Given this list of marker genes ODF4, TSPYL2 (TSPY like 2), ZRANB2, CALML5, ABAT, LRGUK, KRTAP1-5, MIR155HG, TNFSF9, DUSP2, CCDC177, IRF8, ZNF287, MAP3K8, ADGRB2, CPNE5, ADIRF, IGFBP7-AS1, MAGEA6, TPBG, LRRC61, EXT1, LINC02381, G0S2, PLA1A, CDKN2A, CPEB1-AS1, POLR1C, PDGFA, SOCS2, CDKN2B, C3orf36, ZNRF4, DEPDC7, SOST, NETO2, WDR86, ADA, SPRR2C, KHDC1L, RAB21, GSX2, DENND4A, PNLIPRP3, DUOX2, TNF, RPGR (NCBI Gene Id 6110), ZIM3, EPHB4, FSD1L, NDUFAF2, TRIP10, POLR3C, TFPI2, CD320 (CD320 molecule), TLR4, RHCG, GPRC5A, NFKBIZ, IFNG, CDK2, GADD45A, STEAP1B, CCNYL2, NEFH, INSM2, UBE2E1, VXN, FXYD6, SVIL, SLC5A1, TMEM243, IL36B (interleukin 36 beta), FOS, RALA, CNKSR3, NOCT, ARHGDIG, SLC24A2, RAB39B, ATG101, SEMA3A, MAPKBP1, TESC, CNFN, SIK1, PAPPA2, LIF, SENP5, PCDHB18P, LRRC49, RPL21, IQCG, PGLYRP2, HECW2, PIM2, ADORA2B, ZFPM2, RAB30-DT, POPDC2, BCL2L1, NEMP1, MSTN, CREB3L1, GPR101, CLCF1, ARL5B, SIM2, SCARNA2, FOXP1, OLFM4 (NCBI Gene Id 10562), SELENOM, RGS16, CD70, HSD3B2, CREB5, KLF2, NDE1, ECD, DUSP4, PRKCZ, SLC2A5, NODAL, TPM2, TLCD3A, HPN, LOXL1, LIPG, SAMD10, OXTR, PERP (NCBI Gene Id 64065), SELENOK, PAX2, PLEKHA3, TDH, MED14, DUSP1, SCART1, PROSER2, EGR3, DYRK3, TRAF4, ETS2, CAPN8, C20orf96, IL23A, BICDL1, MPZL1, DDN, ZNF239, C7orf33, KIF14, CYRIA, ACOT11, AGT, IL12A, NOTCH3, IRX3, TARP, H4C7, LINC-PINT, MAD2L1, KHDRBS3, TMEM156, FJX1, NLRP7, NIM1K (NIM1 serine/threonine protein kinase), BCL2L14, VSIG4, ZXDA (NCBI Gene Id 7789), TRIM69, CAMK1G, BACH1, SAR1A, CD3D, DSCR4, FH, LINC00158, BHLHE22, CSF2, IL36G, CPNE8, ARHGAP4, PBX4, PRPF40B, MPHOSPH6, RAB3IP, IL12RB2, IFNL1, CRADD, C10orf95, ALKBH3-AS1, MFSD3, NEDD4L, SCHIP1, ZNF506, here is a description of the gene set: Human Gene Set: GSE2706_LPS_VS_R848_AND_LPS_8H_STIM_DC_DN Genes down-regulated in comparison of dendritic cells (DC) stimulated with LPS (TLR4 agonist) at 8 h versus DCs stimulated with LPS (TLR4 agonist) and R848 for 8 h. Toll like receptors (TLRs) sense microbial products and initiate adaptive immune responses by activating dendritic cells (DCs). Since pathogens may contain several agonists we asked whether different TLRs may synergize in DC activation. We report that in human and mouse DC TLR3 or TLR4 potently synergize with TLR7, TLR8 or TLR9 in the induction of selected cytokine genes. Upon synergistic stimulation, IL-12, IL-23 and Delta-4 are induced at levels 50-100 fold higher than those induced by optimal concentrations of single agonists, leading to enhanced and sustained TH1 polarizing capacity. Using microarray analysis we show that only 1.5% of the transcripts induced by single TLR agonists are synergistically regulated by combinations of TLR4 and TLR8 agonists. These results identify a combinatorial code by which DCs discriminate pathogens and provide (suggest) a rationale to design adjuvants for TH1 responses. Series_overall_design: 3 untreated, 3 treated with LPS at 2h, 3 treated with LPS at 8h, 3 treated with R848 at 2h, 3 treated with R848 at 8h, 3 treated with LPS + R848 at 2h, 3 treated with LPS + R848 at 8h from publication Napolitani G, Rinaldi A, Bertoni F, Sallusto F, Lanzavecchia A (PMID 15995707) species: Homo sapiens